Given this list of marker genes Ablim2, Ablim1, Cfl1, Nck2, Carmil2, Fscn1, Clrn1, Rac1, Itgb1, Fgd4, Akirin1, Twf1, Rhod, Spef1, Plce1, Actr2, Capzb, Pmp22, Pxn, Carmil1, Slit2, Vav3, Mtor, P2ry12, Golph3, Abi2, Hsp90aa1, Fer, Abi3, Plxnb3, Cdh13, S1pr1, Pik3r1, Nckap1, Bin3, Ablim3, Dmtn, Hdac4, Ajuba, Actr3, Auts2, Arhgef4, Nup85, Frmd7, Cyfip1, Rac2, Avil, Spata13, Brk1, Was (NCBI Gene Id 97782), Dnm2, Arhgef6, Atp7a, Sh2b1, Hrg, Wasf3, Mstn (NCBI Gene Id 17700), Cdc42, Arhgef7, Aqp1, Epha2, Wnt1, Nck1, Whamm, Vav2, Twf2, Parvb, Arpc2, Ccdc88a, Kit, Vcl, Wasf2, Ptpro, here is a description of the gene set: Formation of a lamellipodium, a thin sheetlike extension of the surface of a migrating cell. Mouse Gene Set: GOBP_LAMELLIPODIUM_ASSEMBLY species: Mus musculus